Given this list of marker genes CTSW, PRNP, PREP, PRSS23, CFAP44 (NCBI Gene Id 55779), ADAMTS3 (ADAM metallopeptidase with thrombospondin type 1 motif 3), ST14, ST20, HMSD, PLAU, PCOLCE, CTSA, USP17L7, CAPN15, ANXA2, GZMA, FOLH1B, SPPL2B, MBTPS2, PIK3IP1, PSMB6, PRSS57, TMPRSS15, MMP20, SLCO1B3, RHBDD3, CPN1, AEBP1, REN, SFRP1, PRRG2, OTUD3, METAP2, GGTLC1, PINK1, ADAM9, ADAMTSL2, TIMP4, CPVL, PMPCA, F3, GGT1, KLK15, MASP2, CASP4, PIP, CHMP1A, PRSS46P, SERPINE1, ADRM1, PEPD, GGT2P, PSMB9, CST5, OVCH2 (ovochymase 2), PRPF8, PRSS48, KLK7, PCSK4, CPM (NCBI Gene Id 1368), RNPEPL1, ADAM22, SPINK13, SORL1, USP48, CELA1, CTSE (cathepsin E), PGA5, CAPN1, LPA, COL6A3, BACE1, HPN, ADAM15, CAPN14, LACTB, TMPRSS11D, SEC11A, TMPRSS3, USP7, USP44, CPB1, UQCRC2, OTUD5, PAPPA2, PEBP1, SERPINB9, KLK9, PIGU, ADAM32, TMPRSS11B, DPP9, PRSS8, MMP13, ATP23, ASRGL1 (asparaginase and isoaspartyl peptidase 1), RBP3, DDI1, NLRP12, USP51, PLAT, SIMC1, PRRG3, USP12, ADAMTS14, USP6, MMP28, GZMB, EIF3F, STAMBPL1, AGBL3, COPS5, ADAMTS15, PSMB8, CTSF, KLK14, USP9Y, UNC5CL (unc-5 family C-terminal like), ADAMTS7, ITIH4, SPINT1, UBAC2, SCRN3, APEH, USP11, CST9, ITIH1, ADAM23, PRSS22, NPEPL1, RECK, SENP2 (NCBI Gene Id 59343), MAPK12, CARD16, DHH, ZC3H12A, MINDY3, MMP23B, ADAMTS8, LONP2, USP19, SERPINA6, ATXN3L, AZU1, GGT5, ADAMTS10, CPZ, WFDC8, TPSD1, CPXM2, HINT1, SPOCK3, PRSS54, GGT6 (gamma-glutamyltransferase 6), PGA3, YME1L1, USP31, UCHL5, KNG1, ADAM10, ADAM2, MMP8 (matrix metallopeptidase 8), ADAM12, MBTPS1, OTUD6A, OTUB2, TFPI, USP17L5, ADAM20, WDR20, DDI2, CARD8, BST2, PSMB7 (proteasome 20S subunit beta 7), BIRC7, C1RL, PHEX, CST6, PCSK6, ADAMTS20, TMPRSS11F, PGPEP1L, F7, PRSS45P, SEC11B, ESPL1, USP35, CST7, F2, GAPDH, NLRP7, WFDC6, DPEP3, SERPINB2, RHBDD1 (NCBI Gene Id 84236), CAST, PRRG1, CLCA1, USP4 (NCBI Gene Id 7375), MMP16, CASP10, FOLH1, PRSS53, PRSS47P, SENP6, CST1, SPINK14, SERPINC1, TMPRSS11A, TMPRSS9 (transmembrane serine protease 9), TNFAIP3, ECE1, FN1, TMPRSS7, THBS1, PCSK2, PI16, SERPINH1, USP36, USP39, USP14, ACTMAP, SPPL3, KLKB1, CTSD, MMP10, EEF1AKMT4-ECE2, SCPEP1, APH1B, CTSO, MMP3, USP26, HGFAC, NRIP2, A2ML1, PRSS56, ACR, HTRA2, PTTG1, SERPINA9, VCPIP1 (valosin containing protein interacting protein 1), SERPINA5, SENP7 (NCBI Gene Id 57337), PM20D1, CPA2, AMZ2, PSME3, GZMH, SSPOP, ADAM21, TPSG1, USP17L13, CRB2, PCSK1, DESI1, PRSS16, SPINT2 (serine peptidase inhibitor, Kunitz type 2), CASP2, SERPINA11, ADAM11, AGBL5, KLK10, CIROP, WFIKKN2, MYSM1, USP17L19, USP43, USP30, NLRC4, PSME4 (proteasome activator subunit 4), SPINK6 (serine peptidase inhibitor Kazal type 6), SERPINB4, SPG7, TMPRSS5 (transmembrane serine protease 5), USP1 (NCBI Gene Id 7398), CFLAR, OMA1, CORIN, PARL, CFB, PRTN3, MALT1, CTSS, MINDY4B, GPC3, TLL1, GGT7, HGF, FURIN, FAP, KLK13, MINDY2, F9, PLG, CTRC, HPR (haptoglobin-related protein), WFDC5, ENPEP, SVBP, MMP25, FBLN1, CTRB1, PI15, CD109, MST1L, ACE2, USP9X, TIMP3, BCL2L13, COL7A1, WFIKKN1, CPA1, PRSS41, USP32, CNDP2, SPPL2C, MEP1A, CAPN5, XIAP, CFI, NCSTN, NPEPPS, CTSL, TANK, TIMM50, PRSS21, MMEL1, ERAP2, SERPINE3, CASP1, USP3, ATP2A3, SERPINB1 (NCBI Gene Id 1992), KEL, RHBDD2 (rhomboid domain containing 2), SERPINB8, SPINK1, MMP21, BAD, MMP14, LTF, TIMP1, USP17L24 (NCBI Gene Id 728369), C5, CRIM1, USP13, AIM2, CTSK, ITIH2, PROS1, COPS4, WFDC1, MAL, LONP1, LVRN, SERPINF1, USP15, ADAMTS2, ATXN3, SFRP2, AHSG, USP17L18, USPL1, PRSS37, CPA5, JOSD2, ADAM18, ADAM28, PSENEN, ADAMTS16, TMEM59, USP17L2, CMA1, A2M, OTUD7B, WFDC13, APH1A, USP28, SPINK5 (serine peptidase inhibitor Kazal type 5), PIDD1, MST1, RHBDL3, SPINK2, GZMK, SLPI, SERPING1, MIPEP, SERPINF2, WFDC3, SLCO1B7, NLRP1, NRDC, CTSH, ADAMTS4, COL28A1 (collagen type XXVIII alpha 1 chain), SERPINA12, PROC, CASP6, TYSND1, NAALAD2, STAMBP, BIRC5, USP50, USP22, USP18, PCSK7 (NCBI Gene Id 95070), GGT3P, UFSP2, TPSB2, ABCA2 (NCBI Gene Id 23153), USP20, CPQ, SERPINA2, TPP1, SPOCK2, BIRC6, AGBL1, CLPP, OTUD6B, ECE2, PRSS3P2, NAPSA, TMPRSS4, MMP15, SERPINB5, SPRTN, PROZ, ADAMTS17, PRSS51, OTUD1, SPPL2A, PRSS2, USP33, USP21, CTSZ, DPP6, SHH, USP17L22, KLK3, ADAM29, CELA2A, ADAMTS6, KLK8, USP25, AGA, C2, ATG4B, PAPLN, SPINK9, PRSS36, MINDY4, DCD, USP46, SPOCK1, SLCO1B3-SLCO1B7, PDIA3, PITRM1, ADAMTS12, SERPINB12, CELA2B, RHBDL2, WFDC11, CPD, PAPPA, RACK1, CPE, CPAMD8, USP29, GZMM, TGM2, GPAA1 (NCBI Gene Id 8733), CELA3B, PRSS12 (NCBI Gene Id 8492), CAPN13, CTSC, ATG4C, ENDOU (NCBI Gene Id 8909), OTULIN, MEP1B, PRSS58, CPA4, ASTL, CPS1, PSEN2, HMCES, ADGRG6, SPINK7, LXN, CST2, CPA3, ADAM30, LGMN, DESI2, SENP8, ANOS1, PRCP, SERPINI1, RHBDF2, LAP3, PREPL (NCBI Gene Id 9581), CPA6, PRRG4, OTUB1, LTA4H, PRSS27, USP17L11, TINAG, PRSS3, USP17L23, USP10, VSIR, USP54 (NCBI Gene Id 159195), MMP17, EPPIN, NGF, CASP8, SERPINB7, USP17L17, SERPINB3, GBP2, CTSV, BLMH, CPB2, PSMD7, OVCH1, CST11, TPP2, CLPX, UFD1, MMP26, USP17L6P, KLK11 (NCBI Gene Id 11012), KLK1, SERPINA10, RENBP, ADAM8, PRSS33, VASH1, SERPINA1, ADAM19, ADAM33, SMR3B, TMPRSS11E, TASP1, NUDT16, COPS6, WFDC12, ANPEP, C1R, CAPN11, USP42, KLK2, PCOLCE2 (procollagen C-endopeptidase enhancer 2), TRABD2A, CST9LP1, SERPINA3, MMP11, DMWD, UFSP1, MANSC4, BEX3, USP17L21, MMP19, AMBP, FAM111B (NCBI Gene Id 374393), DNPEP, TIFAB, CST9L, CAV1, CAPN9, CPXM1, R3HDML, KLK6, FETUB, CFD, AGBL2, IHH, USP38, MMP9 (NCBI Gene Id 4318), KLK4, ADGB, MMP7, PI3, CASP14, AGTPBP1, METAP1, SERPINA7, MYRF, SERPINB13, BRCC3, SERPINA4, SENP5, KLK12, JOSD1, ERMP1, CASP9, LCN1, C3, SENP1, ITIH6, OTULINL, CST4, GGH, SNCA, ADAMTS13, SCRN2, THOP1, VASH2, USP34, CPNE1, MATCAP2, MME, HSPD1 (NCBI Gene Id 56733), PSMB5, TIMP2, BIN1, PRSS1, SERPINI2, USP53, USP17L10, AGT, ATG4D, BMP1, PSMB11, ADAMTS5, WDR48, CAPN6, WFDC9, CLCA2, MMP2, APLP2, USP5, USP24, KDM8, C1S, CTRL, AMZ1, AOPEP, CAPN10, CSTL1 (NCBI Gene Id 149915), USP45, USP17L15, CASP5, CAPNS1, CELA3A, UCHL3, FAM111A, WFDC2, PRSS55, NUP98, DPEP2, ITIH5, IMMP2L, HTRA3, USP37, CARD17P, CAPN7, YBEY, UCHL1, RARRES1, EBAG9, PSEN1, YOD1, LMLN, CTSG, SPP2, CLCA4, SEC11C, CAPN8 (NCBI Gene Id 644151), PSMF1 (proteasome inhibitor subunit 1), RCE1, PM20D2, TPSAB1, CASP8AP2, MMP27, ASPRV1, PIGK, ECEL1, DPEP1 (dipeptidase 1), ADAM7, F11, DPP3, MPND, PSME2, ADAMTS19, CST3, CTRB2, ATG4A, CAPN2, WFDC10A, AFG3L2, PGC, USP49, HP, CAPN3, RHBDL1, SPINK8, IDE, PRSS50, GGTLC2, PMPCB, SERPINE2, USP16, RHBDF1, IMMP1L, TFPI2 (NCBI Gene Id 7980), XPNPEP3, TRHDE, WFDC10B, PSMA6, JMJD7, CAPNS2, SENP3, OTUD7A, HTRA1 (NCBI Gene Id 5654), SPINT4, PARK7, DPP8, TMPRSS6, NKX3-1, NLN, TMPRSS13, CNDP1, F12, SERPINB6, TMPRSS12, EIF3H, USP17L1, ADAMTS9, CASP7, CTSB, ZRANB1, USP8, PRSS38, USP27X, OTUD4, RELN, NPEPPSP1 (NCBI Gene Id 440434), C3P1, CAPN12, TLL2, PCSK9, CYLD (CYLD lysine 63 deubiquitinase), CSN2, CASP3, APP, NOD1, TINAGL1, OPRPN, USP2, PCSK5, SERPINB11, TMPRSS2, XPNPEP1, SCRN1, ADAMDEC1, NRIP3, C4A (complement C4A (Chido/Rodgers blood group)), CPO, MMP12, ACE, ADAMTS18, RNPEP, PSME1, ZUP1 (zinc finger containing ubiquitin peptidase 1), C4B, ZMPSTE24, ITIH3, PRSS29P, UMODL1 (uromodulin like 1), USP17L4, USP17L8, DPP10, HTRA4, F10, HM13, BACE2, ROCK2, USP17L3, MATCAP1, USP40, KLK5, NDUFA13, VCP, CST8, USP17L12, MASP1, NLRP3, USP47, SERPINB10, ADAM17, PSMB10, ALG13, PSMD14, DPP4, ADAMTS1, COL4A3, HABP2, XPNPEP2, SMR3A, NAALADL1, PYCARD, MMP24, MINDY1 (MINDY lysine 48 deubiquitinase 1), DAG1, SERPIND1, PAN2, MMP1, HRG, LNPEP, SPINK4, TGFB1 (NCBI Gene Id 7040), TRABD2B, PRSS42P, APAF1, PZP, PGA4, NAIP, CSTB, USP17L20, SPINT3, AGBL4, DPP7, KY, ERAP1, CARD18, GBP5, PCSK1N, ELANE, BAP1, METAP1D, CSTA, CASP12, GGTLC3, PGPEP1, here is a description of the gene set: Human Gene Set: GOMF_PEPTIDASE_ACTIVITY studied in species Homo sapiens Catalysis of the hydrolysis of a peptide bond. A peptide bond is a covalent bond formed when the carbon atom from the carboxyl group of one amino acid shares electrons with the nitrogen atom from the amino group of a second amino acid.